The following is a description of a gene set: Removal of the transcription factor SAP1a member of the Ternary Complex Factor (TCF) group of transcription factors which in conjunction with Serum Response Factor (SRF) has been shown to have a profound effect on positive selection in the thymus. When another TCF Elk1 is knocked out in mice there is no effect on positive selection unless it is on a Sap1a KO background where the phenotype is very severe. We have stimulated isolated double positive T cells (DPs) with anti-CD3 to mimic positive selection and compared basal and stimulated transcription across the four genotypes to discover the downstream targets of Sap1a involved in positive selection. studied in species Homo sapiens from publication Costello P, Nicolas R, Willoughby J, Wasylyk B, Nordheim A, Treisman R (PMID 20554967) Genes up-regulated in untreated double positive thymocytes: wildtype versus ELK1 and ELK4 knockout. Human Gene Set: GSE21546_WT_VS_SAP1A_KO_AND_ELK1_KO_DP_THYMOCYTES_UP, and this is the list of marker genes: HELZ2, CAMK2A, LHFPL2, RTP4, ANKRD33B, CCL5, BIRC2, PADI4, IL15RA, IPMK, MAP3K8, FAR1, IRAK1BP1, ACOD1, PAN2, EDF1, RFFL, MICALL2, ACKR2, DENND1C, NFKBIA, ABCC1, CEP43, IFRD2, RBM6, TAX1BP1, SERTM1, METTL13, STIP1, FAM135B, DLD, UBQLNL, CCAR1, TUT1, RBPJ, SQSTM1, IFIT2, PPFIA3, ZMYND15, LZTFL1 (NCBI Gene Id 54585), HIVEP3, NFKBIB, OC90, CEP170, ANO6, RBBP5, TMEM63A, TRIM21, C14orf28, LITAF, RGS19, CEMIP2, BCR, ESYT2, AGRP, ENPP4, RIOX2, ATP11C, DBN1, RAB20, TIRAP, RBFOX3, JUNB, IBTK, TBL3, ZNF646, AXDND1, SLC6A7, RAPGEFL1, ATMIN, COG3, CCL4, CDV3, MARVELD2, NR3C2, C4orf54, KCNQ5, TTC21A, DCP1A, LCN2 (lipocalin 2), TCIRG1, HMGA2, TMEM71, GBP7, TMEM47, NFKB1, GSDMD, CLINT1, KRI1, ZBTB7C, ICAM1, KDM3B, ABCB1, MEPCE, CCL13, PIK3R5, LRP2BP, PTGES, CD37 (NCBI Gene Id 951), PARP9, SETX, XAF1, BMAL1, HAS1, MT1E, IQGAP3, ZIM3, ZEB2, AZI2, NFE2L2, YTHDC1, SNX18, LRRC3B, EIF6, HSD17B12, AVPR2, ITPKB, PTPN1, FGF7, LBP, RCCD1, NR4A2, CASP8, TNFRSF17 (TNF receptor superfamily member 17), METTL14, RIGI, MFSD4A, DNAJA2, TRAF3IP2, NMNAT2, FBRSL1, KDM3A, STAT2 (signal transducer and activator of transcription 2), GLRX (NCBI Gene Id 90885), HOMER1, SLC7A7 (solute carrier family 7 member 7), CYBB, NAB1, CMIP, NFKBID (NCBI Gene Id 84807), TMEM132E, IFIH1, IKBKE, CSF2, SLC35D2, FCF1, RHOB, IFIT1B, PILRA, KRT33A, LAMB1, RNF19A, POLR1B, TRIM32, RAP1B, GRHL3, DENR, MGAT4B, PLCB4, STARD5, RHBDF2 (rhomboid 5 homolog 2), NFKBIE, ZSCAN29, IFIT3, CACNB3, DCLRE1C, DDI2, CLDN23, CMPK2, SLC15A3, OR52N4, MPL, UPP1, NBEAL2 (NCBI Gene Id 23218), IWS1 (NCBI Gene Id 55677), ANKRD7, GYS1, GTSF1L, EBI3, TMEM185A, GSAP, POLR2A, MYO3B, HSF4, TAGLN2, TBC1D1, SLC2A6, ATP7A, DUSP16, RELB, MMP1, CH25H, THEMIS2, SMAD4, ZNF263, GPR84, SHISA3, TOR3A, STK40, SMG1